The following is a description of a gene set: Amino acid metabolism species: Homo sapiens Human Gene Set: WP_AMINO_ACID_METABOLISM, and this is the list of marker genes: TAT, WARS1, ACO2, HADH, PDHX, ARG1, PCK1, CTH, GLUD1, SMS, ADH4, GSS, LDHA, IARS1, ASS1, OGDH, P4HA2, SDS, BHMT, IDH1, FAH, ALDH1A1, RARS1 (arginyl-tRNA synthetase 1), CAD, VARS1, OAT, ADH1C (alcohol dehydrogenase 1C (class I), gamma polypeptide), CBS, AOC3, ACADM, GOT1, ALDH7A1, MARS2, HAL, DBH, TPH1, GLUL, CS, PC, GSR, TPO, FH, ARG2, SRM, SUCLG1, HNMT, ACAA1, DDC, FARSB, PKM, HIBCH, ACSS1, TH (tyrosine hydroxylase), PYCR1, ALDH18A1, MDH2, GLS, GCLM (NCBI Gene Id 2730), PDHA1, G6PC2, GPT2, OTC, ADH5, MPST, SDHA, HMGCS2, GOT2, DLD, LARS2, FTCD, AUH, MMUT, PPM1L, HMGCL, CPS1, DLST, MCCC1, EHHADH, ASNS, PNMT, ACLY, HDC, TDO2, HIBADH, ADH7, EPRS1, MAOA, PDK4, MDH1, BCAT1, ODC1